The following is a description of a gene set: species: Mus musculus Any process in which telomerase RNA is transported to, or maintained in, a specific location. Mouse Gene Set: GOBP_TELOMERASE_RNA_LOCALIZATION, and this is the list of marker genes: Dcp2, Dkc1, Tcp1, Exosc10 (NCBI Gene Id 50912), Cct2, Parn, Wrap53, Cct4